Given this list of marker genes NLRP4, XRCC5, STING1, TBK1, DTX4, XRCC6, MRE11, IRF3, NLRC3, IFI16, TREX1, DDX41, PRKDC, here is a description of the gene set: IRF3-mediated induction of type I IFN Human Gene Set: REACTOME_IRF3_MEDIATED_INDUCTION_OF_TYPE_I_IFN species: Homo sapiens